Given this list of marker genes Pla2g4b, Pla2g2a, Pla2g4a (NCBI Gene Id 226493), Crls1, Pla2g2f (NCBI Gene Id 26971), Pla2g2d, Pla2g3, Pla2r1, Lpcat4, Pla2g12a (phospholipase A2, group XIIA), Pla2g4d, Lpcat1, Pla2g10, Pla2g5, Lpgat1, Pla2g4f, Pla2g1b, Pla2g2e, here is a description of the gene set: Mouse Gene Set: REACTOME_ACYL_CHAIN_REMODELLING_OF_PG Acyl chain remodelling of PG studied in species Mus musculus